The following is a description of a gene set: species: Mus musculus Mouse Gene Set: GOBP_NEURAL_TUBE_FORMATION The formation of a tube from the flat layer of ectodermal cells known as the neural plate. This will give rise to the central nervous system., and this is the list of marker genes: Adm, Vangl2, Hif1a, Sfrp2 (NCBI Gene Id 99743), Ift57 (NCBI Gene Id 73916), Tsc2, Alx1, Slc39a12, Prkaca, Celsr1, Specc1l, Dlc1, Mthfd1l, Sdc4, Ptk7, Opa1, Pax2, Nog, Stk3, Sufu, Nodal, Mib1, Tgfb2, Bbs4, Kat2a, Sema4c, Arid1a (AT-rich interaction domain 1A), Scrib, Enah, Mthfr, Zic5, Trim71, Lrp2, Mks1, Tmed2, Zeb2, Kdm2b, Grhl3, Arhgap35, Dvl2, Cecr2, Setd2, St14, Cobl, Abl1, Rab23, Kdm2a, Vasp, Tsc1, Kif20b, Hectd1, Rarg, Pax3, Phactr4, Twist1 (twist basic helix-loop-helix transcription factor 1), Glmn, Rala, Lhx2 (NCBI Gene Id 16870), Bmp4, Pfn1, Nup50, Casp8, Fzd3, Sall1, Med12, Lias, Ovol2, Ipmk, Wdr83, Zic2, Prkacb, Ift122, Fuz, Gatad2a, Wnt5a, Shh, Bmp5, Fzd6, Apaf1, Tgfb1, Lmo4, Brd2 (NCBI Gene Id 547337), Cfl1, Deaf1, Tead2, Sall4, Sfrp1, Tulp3, Ift172, Stil, Ift52, Ski, Grhl2 (grainyhead like transcription factor 2), Cc2d2a, Coq7, Gdf7, Casp3, Mthfd1, Folr1, Tctn1, Prickle1, Rps7, Cthrc1, Ptch1, Abl2, Kdm6a, Traf6 (NCBI Gene Id 99098, TNF receptor-associated factor 6), Rgma, Spint2 (NCBI Gene Id 97345), Lrp6, Tfap2a, Nckap1, T (NCBI Gene Id 20997), Shroom3, Spint1, Bcl10, Brpf1, Smarca1, Plxnb2, Cited2, Tgif1, Bmp7, Map3k7, Cdk20, Sec24b, Luzp1, Stk4, Rock2, Cluap1, Rara